Given this list of marker genes PRNP, CAPN3, KLF4, BIN2, GLRX, CCNL1, IER3, FCRL2, SAT1 (NCBI Gene Id 6303), ACAP2 (ArfGAP with coiled-coil, ankyrin repeat and PH domains 2), FOS, ARHGEF6, ZBTB20, PNISR, SFPQ, HOMER3, FGL2, FYN, DUSP22, ANXA1, RGS2, ARGLU1, HMGB2 (NCBI Gene Id 3148), TCF7, PMAIP1, JUNB, GOLGA8N, MSL1, MARCKS, EIF4A1, SUGP2, SORL1, MS4A6A, SRSF7, CNTNAP2, DUSP1, FNBP4, ID2, KLRK1, SULT1A2, MNDA, here is a description of the gene set: Human Gene Set: BILBAN_B_CLL_LPL_DN from publication Bilban M, Heintel D, Scharl T, Woelfel T, Auer MM, Porpaczy E, Kainz B, Kröber A, Carey VJ, Shehata M, Zielinski C, Pickl W, Stilgenbauer S, Gaiger A, Wagner O, Jäger U, German CLL Study Group (PMID 16617321) species: Homo sapiens Lipoprotein lipase (LPL) is a prognostic marker in B-cell chronic lymphocytic leukemia (B-CLL) related to immunoglobulin V(H) gene (IgV(H))mutational status. We determined gene expression profiles using Affymetrix U133A GeneChips in two groups of B-CLLs selected for either high ('LPL+', n=10) or low ('LPL-', n=10) LPL mRNA expression. Selected genes were verified by real-time PCR in an extended patient cohort (n=42). A total of genes discriminated LPL+ from LPL- B-CLLs. Of these, the top three genes associated with time to first treatment were Septin10, DMD and Gravin (P</=0.01). The relationship of LPL+ and LPL- B-CLL gene expression signatures to 52 tissues was statistically analyzed. The LPL+ B-CLL expression signature, represented by genes was significantly related to fat, muscle and PB dendritic cells (P<0.001). Exploration of microarray data to define functional alterations related to the biology of LPL+ CLL identified two functional modules, fatty acid degradation and MTA3 signaling, as being altered with higher statistical significance. Our data show that LPL+ B-CLL cells have not only acquired gene expression changes in fat and muscle-associated genes but also in functional pathways related to fatty acid degradation and signaling which may ultimately influence CLL biology and clinical outcome. Genes down-regulated in B-CLL (B-cell chronic leukemia) samples expressing high levels of LPL compared with those expressing low levels of the gene.